Given this list of marker genes GP1BA, MCFD2, PTPRJ, SERPINE1, SLC37A4 (NCBI Gene Id 84965), BLOC1S3 (biogenesis of lysosomal organelles complex 1 subunit 3), HPS4, ITGB3, VWF, NBEAL2, F10, GP9, F11, BLOC1S5, GP6, F2, F13A1, APOLD1 (apolipoprotein L domain containing 1), TPM4, F7, SLFN14, ITGA2B, FYB1, LMAN1, MYH9, GP1BB, F8, F5, F13B, PRKACG, DIAPH1, FLI1, PLAU, PRLR, DTNBP1 (dystrobrevin binding protein 1), GNE (glucosamine (UDP-N-acetyl)-2-epimerase/N-acetylmannosamine kinase), RASGRP2, HPS5, here is a description of the gene set: Menorrhagia Human Gene Set: HP_MENORRHAGIA Prolonged and excessive menses at regular intervals in excess of 80 mL or lasting longer than 7 days. species: Homo sapiens